The following is a description of a gene set: studied in species Homo sapiens Human Gene Set: GSE8678_IL7R_LOW_VS_HIGH_EFF_CD8_TCELL_UP from publication Joshi NS, Cui W, Chandele A, Lee HK, Urso DR, Hagman J, Gapin L, Kaech SM (PMID 17723218) At the peak of the CD8 T cell response to acture viral and bacterial infections, expression of the Interleukin-7 Receptor (IL-7R) marks Memory Precursor Effector CD8 T Cells (MPECs) from other Short-Lived Effector CD8 T cells (SLECs), which are IL-7Rlo. This study was designed to determine the gene expression differences between these two subsets of effector CD8 T cells. Genes up-regulated in IL7R low effector CD8 T cells versus IL7R high effector CD8 T cells., and this is the list of marker genes: AGFG2, AS3MT, BORCS7, CDK19, GALNT16, MXRA7, EPAS1, TAX1BP3, NEB, TMEM120A, SYTL2, ACOT11, PRKAG2, TUBB2B, FLII, BHLHE40, ESM1, ENTPD1, PTH1R, NRARP, DAPK2, LTB4R, AK3, TRAIP, SYTL3, MTTP, DPM2, CACNA1D, NXT1, SMTN, ITGB2, CA5B, TEX22, PCSK7, ADGRA1, OLFM3, MXD3, GOLM1, CTSD, CEBPG, PIH1D1, PLEC, FLNA, ANXA4, TSPAN32, RRBP1, RD3, EML6, ATP13A2, TSGA10, FAM89B, NUDT17, SNAPC2, STX7, MSC, ATP2A3, PHACTR2, SMDT1, MCUB, ATG4D, CEP72, SLC48A1, RAP2A, TMEM163, ACTG2, TAF12, SEMA4F, P3H4, PIDD1, ENDOD1, PPL, USP6NL, CTNNBIP1, MEGF9, SUMF1, PXYLP1, CCL4, GPX8, STOM, VASN, SPAG1, UCK2, MRPL38 (mitochondrial ribosomal protein L38), OSBPL8 (oxysterol binding protein like 8), DGCR6, PDIK1L, SUSD1, MSL3, UBA6, EMP3, TAF6, MPND, PRF1, HYCC1, C1orf21, PYCARD, SLC5A1, CX3CR1, HRK, KERA (NCBI Gene Id 1256), CLCN5, APOBEC2, NCKAP1, PSMD9, COG1, GZMA, RASGRP2, CDYL, GPD2, KCNJ8, DUSP5, ILK, DOCK5, DDA1, CAPN2, PPP2R5D, FHL2, REEP5, TRAPPC1, BAIAP2, GSAP, ADRB1, SIKE1, ODR4, DCP1B, CLIC5, VPS4A, TRAF3IP1, LARP7, LRP8, SEC14L1, ZEB2, EPN1, KLRG1, DHCR7, EHMT2, SPATA13, PKMYT1, EHBP1L1 (NCBI Gene Id 254102), CHIT1, SMPDL3B, RAP2B, FBXL2, LCMT1, ADAM17, SH3YL1, PAFAH1B2, TSPAN5, CASP7 (NCBI Gene Id 840), FCGR2B, MYADM, CCND3, LPIN1, NEDD4, NFIC, NANS, E2F2, RDM1, F2RL3, LRRC75B, LRRC8C, CRYBG1 (NCBI Gene Id 6763), GAS2L3, PLEKHH3, FKBP10, RAP1GAP2, GPR25, FIG4, LRRC17, MAN1B1, ELOVL7, PRKAB1, C3orf62, S1PR5, PTGR1, BAIAP3, MAST2, MTRES1, OSBPL3, TREX1, CYP17A1, CES4A, PTPN1, SORD, HASPIN, STX2, ELOVL1, IDH2, CELA1, XKR8, KCNT1, GFOD1, L1CAM, VCL (NCBI Gene Id 7414), IL18RAP, PEA15, RASL11B, PRDM1, PTTG1IP